Given this list of marker genes OR5AP2, OR8U1, SLC22A9, RN7SL435P, OR5M13P, SLC22A25, TKFC, MED19, MIR6748, MYRF-AS1, BSCL2, MS4A8 (NCBI Gene Id 83661), OR5AN1, EEF1G, ZDHHC5, DDB1, OR4D7P, FADS3, OR5M9, UQCC3, OR5AS1, OR2AH1P, OR5AP1P, SLC22A6, STX3, MIR6128, SSRP1, OR5D18, MS4A6A, LINC00301, MS4A12, OR8J1, PTGDR2, LPXN, FAM111A, TMEM109-DT, OR9G2P, OR5M5P, RNA5SP341, PRG2, MS4A13, SYT7, OR8L1P, TMEM138 (transmembrane protein 138), MS4A10, OR5M1, ENSG00000255266, OR5M4P, OR5AK3P, OR10Q1, RCC2P6, GLYATL2, RPL29P22, SELENOH, OR5AN2P, DAGLA, OR5BC1P, TMA16P1, OR5M10, SNHG1, RN7SL605P, RNU6-118P, MS4A3, PRPF19-DT, PATL1-DT, OR5M7P, ENSG00000257002, RPLP0P2, OR5G3, OR5M6P, NAA50P1, TMX2, OR8H1, OR5T2 (olfactory receptor family 5 subfamily T member 2), BEST1, OR6Q1, OR9I1, OR5BP1P (NCBI Gene Id 81203), MIR6514, EEF1DP8, OR5J7P, SLC22A10 (solute carrier family 22 member 10), OR8V1P, MS4A14, OR1S1, OR5B10P, CCDC86, SLC15A3, OR4D11, TMEM258, MS4A18, OR5BE1P, VWCE, LINC02739, ENSG00000287264, SCGB1A1, LINC02733, NPM1P35, OR5BR1P, OR5AL1, RN7SL23P, GLYAT, INCENP, PGA3, OR5T1, SNORD22, PLAAT2, SCGB1D2, POLR2G, TCN1, RTN4RL2, WARS1P1 (NCBI Gene Id 341112), MPEG1, SLC43A1, B3GAT3, NXF1, OR8I2, OR4D10, APLNR, OR5T3, CD5, TMEM216, ZP1, OR5BN1P, OR5L1, HNRNPUL2-BSCL2, SLC3A2, OR5W1P, RAB3IL1, GNG3, AHNAK, MS4A1, MTA2, OR8K4P, MS4A19P, C11orf98, SRD5A3P1, LBHD1, OR9Q1, FABP5P7, FAM111B, MS4A15 (membrane spanning 4-domains A15), VN2R9P, OR5G4P, PLAAT4, OR8U3, FEN1, TAF6L, OR5AL2P, OR5BA1P, RPS4XP13, OR5W2, MIR6503, STX5, OR5M3, SNORD25, TTC9C, CCND2P1, OR10Q2P, STX5-DT, OR9G4, OR5F1, OR5B3, LRRC55, SCGB1D4, CYCSP26, SLC22A8, P2RX3, SLC25A47P1, OR5AR1, OR9I2P, OR7E5P, OR5B19P, CCDC86-AS1, RNU6-933P, ZFP91-CNTF, OR10Y1P (olfactory receptor family 10 subfamily Y member 1 pseudogene), MS4A7, UBE2L6, PRG3, MIR6747, ENSG00000299485, INTS5, CHRM1, YPEL4, CSKMT, TUBAP7, WDR74, MS4A6E, HNRNPUL2, OR5AK4P, SNORA57, OR9I3P, OR8I4P, SDHAF2, OR5I1, MIR6746, TMEM132A, SLC22A24, SLC43A3, OR8K3, OR10V1, MRPL16, OR5G1P, OR8K1, VPS37C, GLYATL1, OOSP1, OR8H3, OR5J1P, SCGB2A1, OSBP (NCBI Gene Id 5007), OR5AK2, TUT1, DTX4, GLYATL1P4, OR5D16, OR5M2P, LGALS12, OR8K2P, PRPF19 (pre-mRNA processing factor 19), OR8I1P, RPL5P29, FAM111A-DT, FTH1 (NCBI Gene Id 92182), OOSP4B, OR5M11, OR9G1, OR5L2, OR10AG1, ENSG00000255240, OR5B1P (olfactory receptor family 5 subfamily B member 1 pseudogene), FADS1, ROM1, GLYATL1P2, SAXO4 (stabilizer of axonemal microtubules 4), OR5AK1P, OR5AQ1P, FAM8A2P, RNU6-899P, SNORD30, CBLIF, PATL1, OR5B17, OR5B15P, OR5B12 (olfactory receptor family 5 subfamily B member 12), OR1S2, OR5A2, RN7SL42P, MIR3162, OR5B2, SCGB1D1, SNORD27, RN7SKP259, CPSF7, OR8J3, OR10AF1P, EIF4A2P3, PPIAP42, OR5M12P, LRRN4CL, OOSP2, OR4D6, PGA4, PGA5, OR9Q2, OR5G5P, SERPING1, OR5AZ1P, OR5BD1P, TMEM109, MS4A4A, OR5BL1P, PLAAT5, OR4D9, ZBTB3, MS4A5, LINC02735, RNU6-1243P, MIR611, ZFP91, OR5AO1P (olfactory receptor family 5 subfamily AO member 1 pseudogene, NCBI Gene Id 403272), CTNND1, ANKRD33BP6, TMEM223, MIR1908, OR5F2P, SCGB2A2, FADS2, OR10V3P, OR9L1P, RNU2-2P, OR10AK1P, EML3, RN7SKP192, MS4A4E, OR5A1, OR10V2P, ASRGL1, SNORD26, CNTF, LRRC10B, ENSG00000250230, OR5M8, CD6, SMTNL1, OR8H2, LINC02954, OR5AM1P, RN7SL259P, OR8K5, MIR130AHG, OOSP4A (oocyte secreted protein family member 4A), GANAB, PTTG1P2, MIR4488, GLYATL1P1, TMEM179B, UBXN1, OR9G3P, OR5J2, BTBD18, LINC02705, OR4D8P, FADS2B, MYRF, OR10W1, OR5B21, CYB561A3, TMEM230P2, OR9M1P, MIR130A, OOSP3, CLP1, SNORD28, TRIM51 (NCBI Gene Id 92637), OR5BB1P, OR5BN2P, MS4A2, TIMM10, GLYATL1B, OR5BQ1P, TEX54, OR8J2, TNKS1BP1, here is a description of the gene set: species: Homo sapiens Human Gene Set: chr11q12